Given this list of marker genes Polr2l, Polr2k, Polr2c, Gtf2h1, Gtf2f1 (NCBI Gene Id 98053), Gtf2f2, Ercc2, Polr2g, Polr2e, Rnmt, Gtf2h2, Ercc3, Gtf2h5 (general transcription factor IIH, polypeptide 5), Ncbp2, Ncbp1, Polr2i, Cdk7, Polr2a, Supt5, Rngtt, Mnat1, Polr2d, Polr2b, Gtf2h4, Polr2h, Gtf2h3, Polr2f, Ccnh, here is a description of the gene set: species: Mus musculus Mouse Gene Set: REACTOME_MRNA_CAPPING mRNA Capping